The following is a description of a gene set: from publication Dudziak D, Kamphorst AO, Heidkamp GF, Buchholz VR, Trumpfheller C, Yamazaki S, Cheong C, Liu K, Lee HW, Park CG, Steinman RM, Nussenzweig MC (PMID 17204652) Genes up-regulated in spleen dendritic cells from Flt3L Melanom injected mice: 33D1+ versus DEC205+ subpopulations. Human Gene Set: GSE6259_33D1_POS_VS_DEC205_POS_FLT3L_INDUCED_SPLENIC_DC_UP Dendritic cells (DCs) process and present self and foreign antigens to induce tolerance or immunity. In vitro models suggest that induction of immunity is controlled by regulating the presentation of antigen, but little is known about how DCs control antigen presentation in vivo. To examine antigen processing and presentation in vivo we specifically targeted antigens to the two major subsets of DCs using chimeric monoclonal antibodies. Unlike CD8+ DCs that express the cell surface protein CD205, CD8- DCs, which are positive for the 33D1 antigen, are specialized for presentation on MHC class II. This difference in antigen processing is intrinsic to the DC subsets and associated with increased expression of proteins associated with MHC processing. studied in species Homo sapiens, and this is the list of marker genes: FLII, EGR2, NUP54, SIPA1L1, NANOS3, CFB, PRDM4 (NCBI Gene Id 11108), CRAMP1, IL27, MIR125A, MAPK8IP3, SOWAHC, RTKN, LRRFIP2, CMKLR1, PDE8A, IL1A, SLC27A4, EML2, OR1D2, NR4A1, MICALL2, RFFL, PDE10A, DTNB, ZC3H12A, SECISBP2, KIF27, CXCL2, ABTB2, PPP1R10, EGLN2 (NCBI Gene Id 54750), CDO1, DYRK1A, PTGES, RBMX, DPEP3, NOTCH2, FPR1, PKP4, OSBP, LCAT, PLA2G4A, KDM5C, NUPR1, BTBD1, TNIP1, TNFAIP3, LRRC8C, TTPAL, MCUB (NCBI Gene Id 55013), RBPJ, MDFIC, KREMEN1, SLC12A4, RAB11FIP1, MBP, GTPBP2, RNF24, GRAMD1A, FCGR2B, SFRP5, TMEM63A, GDF15, CD74, MMP13, DDX54, KDM6B, DMRTC1B, RHBDF2, PTPN23, EREG, SLCO4A1, TMC3, MIR99B, CCL3, TRAF1, OLR1, PGC, AP2B1, HIPK2, PPP1R12A, LRRK2, CHIC2, MIR146B (microRNA 146b), FXYD2, ABI2, F10, LCN2, STARD5, CLINT1, CLDN23, OLFM1, DSEL, SIGLEC1, JAK2, HAS1, ETS2, AHR, CDC42BPA (CDC42 binding protein kinase alpha), MAMLD1, ARHGAP6, RCVRN, NOTCH1 (notch receptor 1), TREM1, BST1, CALCR, FOXN4, TRAF3IP2, SERPINB2, PDGFRB, FMNL2, SLC7A11, ZDHHC2, RBPMS, DUSP8, IFITM1, HPGD, SLC15A3, CRY2, ADORA2A, VEZF1, MGAT4A, NIBAN2, NOS2, ST8SIA4, FN1, PLCB4, GRIA4, PHF13, CCL5, FNDC3B, PIK3R6, POLDIP3, FOSL2, SLC39A14, PPARD, ATG9A, GFI1, ACSL1 (acyl-CoA synthetase long chain family member 1), SEPTIN11, BRPF1, UPP1, SEMA4A, CCL4, MINDY1, SQOR (sulfide quinone oxidoreductase), HTRA4, OSM, AGFG1, IER3, TAL2, CSRNP1, POU2F1, SRGN, NFAT5, SLC7A2, PRKCD, PTGS2, PHLDA1, STRN4, MAML1, CXCL13, SNX25, EGR1, RABGEF1, F3, TNFRSF1B, NOL12, IL1B (NCBI Gene Id 3553), STIM2, EDN1, SPACA6, TLR7, CD33